Given this list of marker genes Eif2ak3, Atg14, Nuak2, Prkag1, Mndal, Plin2, Gck, Prkag2, Trp53, Pick1, Becn1, Ywhag, Pmaip1, Ifi203, Kat5, Ifi214, Sh3glb1, Pik3r4, Sesn3, 4921509C19Rik, Sesn2, Szt2, Higd1a, Kptn, Slc7a5, Ifi203-ps, Xbp1, Mybbp1a, Cpeb4, Ifi207, Prkag3, Bcl2, Rrp8, Prkaa2, Gm14151, Stk-ps2 (serine/threonine kinase 2), Itfg2, Chka, Bhlha15, Sesn1, Hspa5, Slc2a1, Plin3, Mtmr3, Nfe2l2, Zc3h12a, Prkaa1, Tbl2, Ifi208, Ifi206, Ifi213, Pik3c3, Ifi209, Sirt1, Kics2, Ywhaz, Suv39h1, Upp1, Foxo3, Asns, Atf4, here is a description of the gene set: studied in species Mus musculus Any process that results in a change in state or activity of a cell (in terms of movement, secretion, enzyme production, gene expression, etc.) as a result of deprivation of glucose. Mouse Gene Set: GOBP_CELLULAR_RESPONSE_TO_GLUCOSE_STARVATION